Given this list of marker genes LAMB3, HLA-DQB1, NOS1, RIC1, COBLL1, ARHGEF38, SLC5A1, TYMP, MYO5B, ALDOB, LAMC2, CTRC, CDH1, LMNB1, IRF6, EFL1, MSX1, NECTIN1, DNAJC21, POLG, GET4 (NCBI Gene Id 51608), LAMA3 (laminin subunit alpha 3), SBDS, SLC7A7, SAR1B, ATP6V0A1, DLX4, SAA1, CRLF1, COL7A1, DLG1, PDGFRA, ARHGAP29, BMP4, TP63, LIPA, COX4I2, ACTG2, HLA-DQA1, SPINK1, FOCAD, MMP1, here is a description of the gene set: Malnutrition species: Homo sapiens Human Gene Set: HP_MALNUTRITION A deficiency in the intake of energy and nutrients.